Given this list of marker genes Rspo4, Tbl1x (NCBI Gene Id 21372), Pin1rt1, Tbl1xr1, Csnk1g2, Xiap, Cdc73, Ubr5, Depdc1b, Ppm1n, Csnk1g3, Frat1, Sfrp1, Src, Sulf2, Zeb2, Atp6ap2, Ccdc134, Amer1, Fgfr2, Ankrd6, Pbxip1, Wnt3, Aspm, Dlx5, Ruvbl1, Bmp2, Peg12, Spin4, Sbno1, Cdh3, Reck, Wnk1, Rnf220, Atp6v1c2, Gpc5, Nkd1, Csnk2a1, Fgf2 (NCBI Gene Id 14173), Wnt3a, Tmem198b, Fgf9, Rnf146, Yap1, Daam2, Wnt5a, Sema5a, Abl1, Dkk2, Wnt5b, Tmem132a, Gid8, Ppp2r3a, Trpm4, Kank1, Gskip, Lrrk2, Vps35, Thra (NCBI Gene Id 319227), Wls, Sulf1, Potefam3b, Map3k1, Fgf10, Tnks2, Abl2, Col1a1, Rspo3, Dixdc1, Csnk1d, Ctdnep1, Atp6v0c, Ccn4, Lgr5, Lgr4, Lmx1a, Potefam3a, Fzd9, Scel, Smad3, Rbpj, Tgfb1, Gpc3, Tert, Lef1, Crbn, Dab2, Fam53b, Sox4, Eda, Plekha4, Smarca4, Csnk1g1, Ankrd66, Caprin2, Tnfaip3, Ppm1a, Adgra2, Nfkb1, D1Pas1, Zbed3 (NCBI Gene Id 72114), Lrrk1, Zranb1, Ptk7, Csnk1e, Vcp, Usp47, Mesd, Wnt10b, Ccar2, Disc1 (disrupted in schizophrenia 1), Ror2, Dapk3, Ddx3x, Prdm15, Ppm1b, Ilk, Mllt3, Bambi, Rspo2, Wnk2, Fgfr3, Hhex, Usp8, Ube2b, Gprc5b, Tmem9, Macf1, Ttc21b, Lypd6, Tmem198, Sfrp4, Lbx2, Shh, Jrk, Egf, Nle1, Sfrp2, Dact1, Tnks, Spin1, Lgr6, Sall1, Usp34, Bmal1, Egfr, Rspo1, Pin1, Rps12 (ribosomal protein S12), Mbd2 (NCBI Gene Id 17191), Nrarp, Tlr2, Adnp, here is a description of the gene set: studied in species Mus musculus Any process that activates or increases the frequency, rate or extent of Wnt signal transduction. Mouse Gene Set: GOBP_POSITIVE_REGULATION_OF_WNT_SIGNALING_PATHWAY